Given this list of marker genes Cdca8, Mrgprb1, Pik3c3, Birc5, Tas1r2, Rab11fip3, Plk1, Tas2r124, Cxcr5, Rab11fip4, Klhl9, Drd3, Rab11a (RAB11A, member RAS oncogene family), Wnk1, Igf1r, Incenp, Calm2, Git1 (GIT ArfGAP 1), Svil, Kif20b, Becn1, Fsd1, Aurka, Racgap1, Tex14, Klhl21, Tas2r102, Uvrag, Bcl2l1, Calm3, Cit, Pkp4, Cdc25b, Kif23, Ccp110, Plk3, Zfyve26, Entr1, E2f7, Cdc42, Aurkb, Chmp3, Ankrd53, Prkce, Birc6, Pin1, Myo19, Pkn2, Kif13a, Map9, Rhoa, Cenpv, Cul3, Vps4a, Sstr5, Zfyve19, Exoc7, Aurkc, Tas2r121, Spast, Nup62, Arf6, Calm1, Drd2, Setd2, Sh3glb1, Prpf40a, Chmp4c, Cetn2 (NCBI Gene Id 93784), Gipc1, Ccdc66, Cspp1, Kif3b, Klhl13, Cdc14b, Ahctf1, Cdc14a, Map10, Prc1, Kif20a, Rxfp3, Atxn10, Bbs4, Ect2, Cdc6, Pik3r4, E2f8, Kif14, Pdxp, Brca2, Poldip2, here is a description of the gene set: Mouse Gene Set: GOBP_REGULATION_OF_CYTOKINESIS studied in species Mus musculus Any process that modulates the frequency, rate or extent of the division of the cytoplasm of a cell and its separation into two daughter cells.